Given this list of marker genes Plk1, Eef1e1, Tipin, Kat5, Abraxas1, Dgkz, Rhno1 (NCBI Gene Id 72440), Sox4, Cdc5lrt6, Gigyf2, Snai1, E2f1, Grb2, Ankrd1, Wdr76, H2ax, Nek11, Chek2, Donson, Ifi211, Hinfp, Babam2, Msh2, Parp9, Smyd2, Cdc5lrt1, Map3k20, Hic1, Bard1, Dtl, Ppm1d, Nop53 (NCBI Gene Id 98700), Ing4, Pttg1ip, Yju2, Stk33, Brcc3dc, Zfp830, Ccar2 (cell cycle activator and apoptosis regulator 2), Blm, Atad5, Mif, Eme2, Cdc5l, Batf, Ppp1r10, Ifi205, Ppp2r5c, Paxip1, Prap1, Rad17, Dtx3l, Creb3l1, Rfwd3, Bid, Sesn2, Rpa2, Casp2, Tfap4, Kdm1a, Clspn, Cdk5rap3, Rps6ka6, Atrx, Zmpste24, Ndrg1, Brca1, Brca2, Taok3, Wac, Atr, Wnt1, Uimc1, Bcl3, E2f7, Twist1, Mbtps2, Cdc5lrt8, Ercc6, Mdm4, Topbp1, Ints7, Nek1, Pmaip1, Rad9b, Chek1, Sde2, Rad9a, Sirt1, Mre11a, Mad2l2, Fbxo4, Pidd1, Mbd4, Dot1l, Foxm1, Myo6, Cdkn2a, Spred2, Spred1 (sprouty protein with EVH-1 domain 1, related sequence), Brsk1, Prkdc, Stk38, Brcc3, Cdc5lrt5, Ticrr, Cdc5lrt9, Trp53, Abl1, Rps27l, Rnf8, Mdm2, Trex1, Taok2, Pcbp4, Taok1, Cul4a, Yap1, Babam1, Casp9, Dyrk1a, Cdkn1a, Cd44, Cd74 (CD74 antigen (invariant polypeptide of major histocompatibility complex, class II antigen-associated)), Mapk3, Rpl26, D7Ertd443e, Etaa1 (Ewing tumor-associated antigen 1), Mus81, Cry1, Ptprv (NCBI Gene Id 64447), Npm1, Atf2, Hus1b, Clock, Atm, Snai2, Ptpn11, Atrip, Fzr1, Trp53bp1, Rbm38, Hus1, Ccnd1, Brd4, Tti1, Zfp385a, Cdk1, Cdc5lrt7 (cell division cycle 5 like, retrotransposed 7), Xpc, Rnaseh2b, Foxn3, Prpf19, Ufl1, Ndufs6, Ddx5 (NCBI Gene Id 72118), Sp100, Syf2, Nbn, Pla2r1, Rint1, Usp10, Psmd10, Cdc5lrt10, Lyn, Acer2, Ier3, Znhit1, Ifi204, Rad51, Foxo4, Rad1, Fancd2, Ccng1, Cdc14b, Cdc5lrt4 (NCBI Gene Id 668191), Eif2ak4, Fbxo31, Mapk14, Dyrk3, Triap1, Cops3, Pml, Kmt5a, Muc1, Cep63, Gnb1l, Mbtps1, Trim39, Cradd, Eme1, Gadd45a, Mrnip, Fem1b, Marchf7, Foxo3, Usp28, Tiprl, Hipk2, here is a description of the gene set: species: Mus musculus Mouse Gene Set: GOBP_SIGNAL_TRANSDUCTION_IN_RESPONSE_TO_DNA_DAMAGE A cascade of processes induced by the detection of DNA damage within a cell.